The following is a description of a gene set: species: Mus musculus electronically inferred by orthology from the curated human pathway This event has been computationally inferred from an event that has been demonstrated in another species.<p>The inference is based on the homology mapping from PANTHER. Briefly, reactions for which all involved PhysicalEntities (in input, output and catalyst) have a mapped orthologue/paralogue (for complexes at least 75% of components must have a mapping) are inferred to the other species. Reactome Pathway: mRNA 3'-end processing part of: Processing of Capped Intron-Containing Pre-mRNA, and this is the list of marker genes: Rps27a, Thoc6, Srsf3, Hnrnph1 (NCBI Gene Id 59013), Sarnp, Polr2b, U2af1l4 (NCBI Gene Id 233073), Fip1l1, Polr2e, Thoc3, Snrpg, Prr3, Rbm17, Rnps1, Clp1, Polr2c, Snrpf, Sugp1, Snrpn, Ddx39a, Alyref, Papola, Ppp1ca, Sf3a3 (NCBI Gene Id 75062), Wdr33, Tut1, Upf3b, Sf3b5, Srrt, Papolg, Snrpa1, Cpsf3, Magohb, Rbmx, Polr2i, Ubb (ubiquitin B), Hnrnpr, Cdc40, Thoc7, Dhx15, Srsf10, Pcbp1, Casc3, Snrpc, Srsf5 (NCBI Gene Id 20384), Gtf2f2, Magoh, Cpsf1, Hnrnpk, Snrpa, Polr2f, Phf5a, Polr2a, Ptbp1, Polr2l, U2af2, Smndc1, Rbm5, Gtf2f1, Srsf8, Hnrnph2, U2surp, Hnrnpf, Pcbp2, Polr2k, Srrm2